Given this list of marker genes Nrarp, Asb15, Asb3, Ankrd10, Ankrd6 (NCBI Gene Id 140577), here is a description of the gene set: species: Mus musculus The process of directing proteins towards the chloroplast, usually using signals contained within the protein. Imported proteins are synthesized as cytosolic precursors containing N-terminal uptake-targeting sequences that direct each protein to its correct subcompartment and are subsequently cleaved. Mouse Gene Set: GOBP_PROTEIN_TARGETING_TO_CHLOROPLAST